The following is a description of a gene set: Mouse Gene Set: GOBP_MIRNA_TRANSCRIPTION species: Mus musculus The cellular synthesis of microRNA (miRNA) transcripts. MicroRNA genes are synthesized as primary (pri) miRNA transcripts and subsequently processed to produce the ~22nt miRNAs that function in gene regulation., and this is the list of marker genes: Prl, Lilrb4a, Lilrb4b, Rara, Srebf1, Rest, Trp53, Nfatc4, Stat3, Rela, Ppara, Srf, Nfib, Jun, Ar (NCBI Gene Id 11835), Nr3c1, Ncor1, Fosl1, Gata2, Tgfb2, Mrtfb, Twist1, Pdgfb, Foxo3, Hif1a, Nr2f1, Esr1, Agt, Myocd, Pparg (NCBI Gene Id 19016), Sox9, Atoh8, Bmyc, Yy1, Egfr, Il10 (NCBI Gene Id 16153), Bmpr1a, Tnf, Tert, Gata4, Hdac4, App, Notch3, Ets1, Apln, Nr1h2, Ctcf, Mrtfa, Tgfb1, Tgfbr1, Ppard, Smad1, Notch2, Bmp2, Nfatc3, Gnl3, Myc, Smad6, Myb, Spi1, Klf4, Srebf2, Gata6, Hdac2, Gata3, Tead1, Ddx17, Bmp4, Pax6, Wt1, Smarca4 (SWI/SNF related, matrix associated, actin dependent regulator of chromatin, subfamily a, member 4), Smad3, Klf5, Fos, Ncor2, Ngfr, Ddx5, Egr1, Smad4, Zfp512b